Given this list of marker genes DPP3, ACTB, DPP7 (NCBI Gene Id 29952), ARPC4, PLEKHB2, ARRB1, GRB2, MVP (NCBI Gene Id 9961), RAB24, here is a description of the gene set: Genes up-regulated in peripheral blood mononuclear cell high responders vs low responders in younger adults (21-35) (high responders) after exposure to trivalent influenza vaccine (TIV), time point 0D. Comment: data from six different cohorts, trivalent vaccine year not specified Annual influenza vaccinations are currently recommended for all individuals 6 months and older. Antibodies induced by vaccination are an important mechanism of protection against infection. Despite the overall public health success of influenza vaccination, many individuals fail to induce a substantial antibody response. Systems-level immune profiling studies have discerned associations between transcriptional and cell subset signatures with the success of antibody responses. However, existing signatures have relied on small cohorts and have not been validated in large independent studies. We leveraged multiple influenza vaccination cohorts spanning distinct geographical locations and seasons from the Human Immunology Project Consortium (HIPC) and the Center for Human Immunology (CHI) to identify baseline (i.e., before vaccination) predictive transcriptional signatures of influenza vaccination responses. Our multicohort analysis of HIPC data identified nine genes (<i>RAB24</i>, <i>GRB2</i>, <i>DPP3</i>, <i>ACTB</i>, <i>MVP</i>, <i>DPP7</i>, <i>ARPC4</i>, <i>PLEKHB2</i>, and <i>ARRB1</i>) and three gene modules that were significantly associated with the magnitude of the antibody response, and these associations were validated in the independent CHI cohort. These signatures were specific to young individuals, suggesting that distinct mechanisms underlie the lower vaccine response in older individuals. We found an inverse correlation between the effect size of signatures in young and older individuals. Although the presence of an inflammatory gene signature, for example, was associated with better antibody responses in young individuals, it was associated with worse responses in older individuals. These results point to the prospect of predicting antibody responses before vaccination and provide insights into the biological mechanisms underlying successful vaccination responses. species: Homo sapiens Human Gene Set: HIPC_SIGNATURES_PROJECT_PBMC_TRIVALENT_INFLUENZA_VACCINE_HIGH_RESPONDERS_VS_LOW_RESPONDERS_YOUNGER_ADULTS_21_35_HIGH_RESPONDERS_0D_UP from publication HIPC-CHI Signatures Project Team, HIPC-I Consortium (PMID 28842433)